Given this list of marker genes TNFRSF11B, IRF4, ZBED2, MYC, IL13, IL5, CCL3, CCR6, IL9 (NCBI Gene Id 3578), here is a description of the gene set: studied in species Homo sapiens Genes with putative STAT5 binding sites; up-regulated by IL2 only in T1 cells (primary thymocytes immortalized by Tax, an HTLV-1 encoded gene). from publication Fung MM, Chu YL, Fink JL, Wallace A, McGuire KL (PMID 15735688) Interleukin-2 (IL-2) mediates cell cycle progression and antiapoptosis in human T cells via several signal transduction pathways. The Tax protein of the human T-cell leukemia virus type I (HTLV-1) deregulates cell growth and alters the role of IL-2 in infected cells. However, Tax-immortalized cells stay dependent on IL-2, suggesting that events besides HTLV-1 gene expression are required for leukemia to develop. Here, IL-2-dependent and -independent events were analysed in a human T cell line immortalized by Tax. These studies show that, of the signaling pathways evaluated, only STAT5 remains dependent. Microarray analyses revealed several genes, including il-5, il-9 and il-13, are uniquely upregulated by IL-2 in the presence of Tax. Bioinformatics and supporting molecular biology show that some of these genes are STAT5 targets, explaining their IL-2 upregulation. These results suggest that IL-2 and viral proteins work together to induce gene expression, promoting the hypothesis that deregulation via the constitutive activation of STAT5 may lead to the IL-2-independent phenotype of HTLV-1-transformed cells. Human Gene Set: FUNG_IL2_TARGETS_WITH_STAT5_BINDING_SITES_T1